Given this list of marker genes ABCA5, MIR144, MIR19B1, MIR33A, LRP1, here is a description of the gene set: studied in species Homo sapiens Human Gene Set: GOBP_REGULATION_OF_REVERSE_CHOLESTEROL_TRANSPORT Any process that modulates the frequency, rate or extent of reverse cholesterol transport.